The following is a description of a gene set: Mouse Gene Set: GOBP_REGULATION_OF_PRESYNAPTIC_CYTOSOLIC_CALCIUM_ION_CONCENTRATION species: Mus musculus Any process that regulates the concentration of calcium in the presynaptic cytosol., and this is the list of marker genes: Tspoap1 (NCBI Gene Id 207777), Cnr1, Npy1r, Cacna1a, Cacna1d, Erc1, Erc2 (NCBI Gene Id 52497), P2ry4, Htr1b, P2ry1, Calb1, Marcksl1, Npy, Rimbp2, Cacnb4, Cdk5, P2ry2, Calb2, Adora1, P2rx2, Ncs1, P2rx1, Sv2b, Cacnb2, Osbpl2, Kcnh1